Given this list of marker genes CD93, DCN, RHOQ, NNT, RER1, OAZ2, TAB3, ARAP3, CD200, KHDRBS1 (KH RNA binding domain containing, signal transduction associated 1), GSTO1, TM7SF3, CASP1, CPT1A, EEA1, ADIPOR2 (NCBI Gene Id 84751), MAGED2, MLLT3, S100A1, HSD11B2, TSC22D1, LCLAT1, NR2C2, LANCL2, KCTD12, ADAM19, AKAP12, FGL2, CYP19A1, CAMLG, TNFSF11, TOR3A, TARS1, AHR, EI24, PSEN2, CCL5, LITAF, NFKB1, TWSG1, NSMAF, CYTH3, IFIH1, PSMB1, CSF2, HSDL2, AP3B1, CHCHD7, CHRNB1, TTC39B, MEMO1, IGF2R, XDH, PHTF2, RNF166, C5, ATF6, AHNAK, ANXA1, AFF2 (NCBI Gene Id 2334), RBPJ, ANKRD46, ACADL, IRF9, SEPHS1, SPARC, SH3BP5, HRK, ETS1, SDHAF1, RYK (NCBI Gene Id 6259), EVI2A, IKZF4, CYP4V2, LAPTM4A, ELOA, BATF3, PTS, EPB41L2, TMEM38B, GYG1, NEDD9, SIX6, TYROBP, ENO3, RGS16, SNAP23, TNFRSF18, BCL2L11 (NCBI Gene Id 150819), PTER, GABARAPL2, LYSMD2, INVS, APC, CRTAM, BCL2A1, MTF2, BCL6, YBX3, PHYH, ABCG2, SLC4A7, TMEM126A, USP18, GFI1, NMB, SOS1, TUT7, MYORG, GABARAPL1, BPHL, CD160, PTTG1, KIT, RHOD, ANXA2, PDCD1, GJB2, AGFG1, PRKCH, TNFRSF9, ITIH5, IFIT1B, RBL2, IRF5, RNF19A, DECR1, SNX1, ACP6, ZFP36L1, IFIT2, HSPA4 (NCBI Gene Id 3308), SAT1, IFI27L2 (interferon alpha inducible protein 27 like 2), CAPN3 (calpain 3), TAP1, TP53BP1, N4BP1, ARPC3, NDFIP2, SLC35D1, CA2, HLA-C, FNBP1, FCER1G, SERF1A, FAH (NCBI Gene Id 2184), ITGAV, BLZF1, ASAH1, TCN2, RNF5, TRAF5, WLS, INPP4A, FASLG, TRIM21, POLA1, HSD17B11, TSPAN32, UGP2, CTLA4, PTPN13, NRP1, CYFIP1, CD9, MYO1E, IRF8, UNC119B, PSMD10, CD244, ENSG00000286190, LAT2, MECP2, NUS1, HP, ERO1B, PLSCR1, TANK, CD81, NAPSA, MFSD4A, MDFIC, VPS26A, MX1, HLA-B, CPD, AMZ2, IRGM, NAMPT, SAA1, XCL1, EGR2, AKTIP, HEXA (NCBI Gene Id 3073), ITM2C, ARL4D, PVT1, TFPI, ADGRL1, here is a description of the gene set: from publication Chan G, Nogalski MT, Bentz GL, Smith MS, Parmater A, Yurochko AD (PMID 20173022) Human Gene Set: GSE19772_CTRL_VS_HCMV_INF_MONOCYTES_UP species: Homo sapiens Human cytomegalovirus (HCMV) induces pro-inflammatory monocytes following infection and we have evidence that phosphatidylinositol 3-kinase is a key mediator in this activation. To begin to address how this signalling pathway is responsible for the functional changes in infected monocytes, we examined the role this pathway played in the transcriptome of infected monocytes. Global transcriptional profiling using cDNA microarrays revealed a significant number of genes were regulated in a PI(3)K-dependent manner, identifying this pathway as a key cellular control point in the conversion of monocytes to an activated pro-inflammatory state following HCMV infection. Genes up-regulated in monocytes: control versus HCMV infection.